Given this list of marker genes Hsf1, Cdv3, Rbm42, Sptlc2, Tubgcp4, Zdhhc20, Cd68 (NCBI Gene Id 12514), Bst2, Kat6b, Plp1, Sod1, S1pr4, Senp5, Tespa1, Eif4ebp2, Rnasek, Coa3, Mrpl33, Eef1b2 (eukaryotic translation elongation factor 1 beta 2), Fos, Suds3, Apoa1, Derl2, Ankrd11, Cdc5l, Smarcc1, Dpysl2, Ubl7, Sp110, Sf1, Lnpep, Ndufs3, Stat3, Lgmn, Brk1, Adar, Plekho1, Zswim1, Akr1a1, Syf2, Glul, Brd3, Dda1, Arrb2, Marcks, Chmp4b, Msra, Mtdh, Eea1, Bsg (NCBI Gene Id 12215), P2ry12, Dnajb9, F11r, Ap1s1, Jtb, Npm3, Nars1, Saa1, Hagh, Eif1a, Sec24c, Mark3, Ppp1r11, Tmem250, Carhsp1, Mef2a, Zfp706, Hdlbp, Mrpl41, Lman2l, Shisa5, Psmd8, Egfl7, Mff, Cfl1, Ppip5k2 (diphosphoinositol pentakisphosphate kinase 2), Rrp1, Ctsz, Fcer1g, Tmed5, Cd74, Cst3, Kpna2, Ltb, Arhgap5, Smarcb1, Gabpb1, Elmo2, Eif4g3, Msn (NCBI Gene Id 97596), Smad4, Isy1, Plaat3, Usp24, Swi5, Cited2, Pgp, Nabp2, Nudc, Hexb, Tmsb10, Ramac, Tle5 (NCBI Gene Id 14797), Larp1, Smc4, Cdc42se1, Timeless, Rpl13a, Coq4, Cep170, Hnrnpa0, Eif3g, Ankfy1, Pak2, here is a description of the gene set: Mouse Gene Set: TABULA_MURIS_SENIS_LIVER_MATURE_NK_T_CELL_AGEING studied in species Mus musculus from publication Tabula Muris Consortium (PMID 32669714)